Given this list of marker genes LZTR1, DBR1, HS2ST1, COL4A3, MIR184, TAOK1, HSF4, CRYGB, EBP, here is a description of the gene set: Anterior polar cataract A polar cataract that affects the anterior pole of the lens. species: Homo sapiens Human Gene Set: HP_ANTERIOR_POLAR_CATARACT